The following is a description of a gene set: studied in species Homo sapiens The aim of this study was to employ a systems-level analysis to elucidate gene expression networks operating in the CD4 T-cell responses which underpin human atopic disease. from publication Bosco A, McKenna KL, Firth MJ, Sly PD, Holt PG (PMID 19414752) Genes up-regulated in resting CD4 T cells: atopy versus healthy. Human Gene Set: GSE14908_ATOPIC_VS_NONATOPIC_PATIENT_RESTING_CD4_TCELL_UP, and this is the list of marker genes: PBXIP1, BICRA, PDE6D, MECP2, CLDND1, PABPC1L, MCUR1, NMT2, PRKAB1, FICD, LYSMD3, CIR1, CPEB4, TMPRSS6, COG5, YIPF5, CCDC97, SLC4A11, ITM2B, TMEM192, CD99, NIBAN1, GAB2, VWA5A, LRRC8D, TNFRSF1B (TNF receptor superfamily member 1B), GFRA1, FSD2 (fibronectin type III and SPRY domain containing 2), ITCH, ST8SIA1, TPGS1, CERS6, GRB2, CHIC1, MXD1, SNAPC1, TCF25, TMEM14A, GSX2, STXBP3, CEMIP2, CA2, RIN3, CD53, FOXP1, CRMP1, DUSP1 (NCBI Gene Id 1843), RAC1, CLASP2, ASB13, RORC, FLOT2, NRF1, PIP4P1, POLI, SFXN4 (sideroflexin 4), REXO4 (REX4 homolog, 3'-5' exonuclease), SEC22B, SFR1, SPRYD3, ITGA3, SMAD7, TSTD1 (thiosulfate sulfurtransferase like domain containing 1), PLA2G12A, IGHMBP2 (immunoglobulin mu DNA binding protein 2), RASL11B, RAB8A, DSC2, KCTD2, DOK1, TRAF4, PTK6, THRB (thyroid hormone receptor beta), TCEAL8, TMEM63A, CNPY4, CTSO, YAF2, TMED3, CHCHD5, PIP4K2A, ZNF414, SNX13, BET1L, NFKBIE, TNN, TMED9, C11orf68, DCTN4, VASP, FAM114A1, SPATA13, WAS, SWAP70, AREL1, ASIC3, UBXN1, RHBDD1, HLTF, ST7L, PPP1R18, ESPN, PPP3CC, MINDY1, COL18A1, UAP1, TERF2, RHOH, SELENOH, ADIPOR2, ARFIP1, POLD4, PRXL2B, CHAC1, HAVCR1, HECA, TESK1, CNKSR1, CD86, GLUD1, CSRNP2 (cysteine and serine rich nuclear protein 2), RTRAF, UFL1, VSIR, PHC2, PPM1J, CARD11, RNF41, SUPT3H, COPZ1, VTCN1, NFKBIZ, GOLGA7, IDH3B, SLC7A14, TMX4, NDRG3, CARD19, C1orf159, NR4A1, AP3M2, RAB21, PPP2R1A, RNF11, STAT1, ZFAND3, CKAP4, CCDC117, GGNBP2, ZNF354B, UBTD1, VAPA, TLK2, ZDHHC7, VRK3, GAS2L3, SH3GLB1, PSAP, RAP2B, SRI, KRTCAP2, PRKCH, AIM2, SMIM3 (NCBI Gene Id 85027), CCPG1, RAB11FIP1, KLC3, NDUFA6, CDIP1, BABAM2 (NCBI Gene Id 9577), TMEM31, COPE, GARS1, NCBP2AS2, TTC3, GALC, VAMP4, CXCR3, S1PR3 (NCBI Gene Id 414320), TPD52, SMYD4, SGPL1, COX17, ACVR2A, FKBP1B, TRMT112, HAPSTR1, KEAP1, NDST1, PARK7, DLG4, SMO, MAPK14, MICU3 (NCBI Gene Id 286097), MRPL33, FAM86B2, RTP3, POGZ, BLVRB, CIAO2B